Given this list of marker genes SEMA7A (semaphorin 7A (JohnMiltonHagen blood group)), ATP7A, FBXO38, DACT1, TRIM23, RAB22A, DHX9, HPCAL1, RBM24, USP53, ATP9A, SLC36A4, PTPRA, USP44, FAM118A, MXI1, HAGH, ENO2 (enolase 2), LIN9, STK3, GFI1, ST6GAL2, PAPSS2, C16orf54, TMEM218, SOAT1 (sterol O-acyltransferase 1), CLCN3, GMCL1, PLXDC2, CNTN6, CCZ1, SMARCD2 (SWI/SNF related, matrix associated, actin dependent regulator of chromatin, subfamily d, member 2), SENP6, RELL1, ZMYM1, HMGB3, TOLLIP, HMGB1, DNAJC6, RASA1, SUGP1, CD164, PRRG4, PKNOX1, HSPA4L, DNM1L (NCBI Gene Id 692222), TSGA10, TMEM71, LANCL1, MRPL13, CNTNAP1, ZNG1A, SENP5, STRN3, ALKBH4, OGFOD2, ILVBL, ABTB3, UBE2G2, ADAM10, NUP107, VGLL4, BTF3L4 (basic transcription factor 3 like 4), MARCKS, DAP3, CYB561D1, KAT2B, ARL6IP1, SUZ12, LRRC40, PTGR3, MGAT4A, RLF, FBXO32, S100A11, ZBTB25, TUBB2B, ABLIM1, MAP1LC3B, YIPF1, RPA1, PODXL2, RPS6KC1, MBD3L1, OSBPL2, OLIG3, PREP, MAP3K13, NCOA1, GLT8D2, NPC2 (NCBI Gene Id 10577), HES6, CHN1, ERICH1, PLCL1, NT5C2, FMNL2, MINDY2, PLEKHO1, RSRC1, DMC1, COASY, RSBN1, SLC28A2, GABPA, GALNT4, RALGPS2, SEC22C, IDH1 (isocitrate dehydrogenase (NADP(+)) 1), TUBB2A, PFKFB1 (6-phosphofructo-2-kinase/fructose-2,6-biphosphatase 1, NCBI Gene Id 5207), GALNT7, PFKP, ITPA, DUT, SLC37A2, ADAM12, LRRC42, SLCO4A1, RBFOX1, FBXL12, SSBP2, MIGA1, SLC25A24, PELI2, DNAJB4, JUP, TAPT1, PIGP, CAMK1G, ZNF148, PPTC7, SPATA6, WIPI2, ANGEL2, DYNC1I2, TSHZ1, ABCA1 (NCBI Gene Id 8371), SLC30A4, INPP5K, DCK, CDK19, SETD3, CERT1, EYA2 (NCBI Gene Id 2139), ARID4A, SMURF2, SUMF1, ZSWIM4, CEP85, NR1D2, TRAPPC2L, HMGXB4, TAB1, PDCD10, SMOC1, PTPN22, TPCN2, C1orf94, MIR1-2, MKRN2, here is a description of the gene set: studied in species Homo sapiens from publication Bhattacharyya S, Deb J, Patra AK, Thuy Pham DA, Chen W, Vaeth M, Berberich-Siebelt F, Klein-Hessling S, Lamperti ED, Reifenberg K, Jellusova J, Schweizer A, Nitschke L, Leich E, Rosenwald A, Brunner C, Engelmann S, Bommhardt U, Avots A, Müller MR, Kondo E, Serfling E (PMID 21464221) Triggering of B cell receptors (BCR) induces a massive synthesis of NFATc1 in splenic B cells. By inactivating the Nfatc1 gene and re-expressing NFATc1 we show that NFATc1 levels are critical for the survival of splenic B cells upon BCR stimulation. NFATc1 ablation led to decreased BCR-induced Ca++ flux and proliferation of splenic B cells, increased apoptosis and suppressed germinal centre formation and immunoglobulin class switch by T cell-independent antigens. By controlling IL-10 synthesis in B cells, NFATc1 supported the proliferation and IL-2 synthesis of T cells in vitro and appeared to contribute to the mild clinical course of Experimental Autoimmune Encephalomyelitis in mice bearing NFATc1-/- B cells. These data indicate NFATc1 as a key factor controlling B cell function. Human Gene Set: GSE21063_CTRL_VS_ANTI_IGM_STIM_BCELL_3H_DN Genes down-regulated in B lymphocytes: control versus stimulated by anti-IgM for 3h.